Given this list of marker genes ADD2, ANGPT1, PSG4, KRT40, PTPRH, NAV2, FAAH (fatty acid amide hydrolase), CMPK1, LIMA1, ABCB1, P2RY6, AP4E1, BACE1, TIMP2, BMP2 (bone morphogenetic protein 2), SNTB1, TRG-AS1, BRWD1, NSG2, CISH, ADAMTS1, MCPH1, BBS12, FLJ38576, FAT4, CST1, SLC38A2, GJA5, TXNDC17, CYP27A1, STMN2, LINC03103, FMO2, TYMP, CRYBG2, ZNF503, BMP7, FOXJ1, HS3ST1, here is a description of the gene set: Genes associated with resistance to doxorubicin. studied in species Homo sapiens Human Gene Set: GYORFFY_DOXORUBICIN_RESISTANCE Up to date clinical tests for predicting cancer chemotherapy response are not available and individual markers have shown little predictive value. We hypothesized that gene expression patterns attributable to chemotherapy-resistant cells can predict response and cancer prognosis. We contrasted the expression profiles of 13 different human tumor cell lines of gastric (EPG85-257), pancreatic (EPP85-181), colon (HT29) and breast (MCF7 and MDA-MB-231) origin and their counterparts resistant to the topoisomerase inhibitors daunorubicin, doxorubicin or mitoxantrone. We interrogated cDNA arrays with 43 000 cDNA clones ( approximately 30 000 unique genes) to study the expression pattern of these cell lines. We divided gene expression profiles into two sets: we compared the expression patterns of the daunorubicin/doxorubicin-resistant cell lines and the mitoxantrone-resistant cell lines independently to the parental cell lines. For identifying predictive genes, the Prediction Analysis for Mircorarrays algorithm was used. The analysis revealed genes best correlated with doxorubicin resistance and genes with mitoxantrone resistance. In an independent classification experiment, we applied our model of resistance for predicting the sensitivity of 44 previously characterized breast cancer samples. The patient group characterized by the gene expression profile similar to those of doxorubicin-sensitive cell lines exhibited longer survival (49.7+/-26.1 months, n=21, P=0.034) than the resistant group (32.9+/-18.7 months, n=23). The application of gene expression signatures derived from doxorubicin-resistant and -sensitive cell lines allowed to predict effectively clinical survival after doxorubicin monotherapy. Our approach demonstrates the significance of in vitro experiments in the development of new strategies for cancer response prediction. from publication Györffy B, Serra V, Jürchott K, Abdul-Ghani R, Garber M, Stein U, Petersen I, Lage H, Dietel M, Schäfer R (PMID 16044152)